Given this list of marker genes IKBKE, RNF185, YTHDF2, MUL1, NLRC5, TREX1, LSM14A, RBM47, USP27X, GIGYF2, IRF7, CNOT7, SAMHD1, MMP12, STING1, TBK1, CACTIN, SMIM30, METTL3, PTPN6, TTLL12, FADD, OAS3, STAT2, PTPN11, PTPN2, WNT5A, YTHDF3, OAS1, TRIM56, IRF3, MAVS, ISG15, USP29, TRIM41, UBE2K, DCST1, MIR21 (NCBI Gene Id 406991), PTPN1, USP18, ADAR, CDC37, TRIM6, ZBP1, EIF4E2, here is a description of the gene set: studied in species Homo sapiens Human Gene Set: GOBP_REGULATION_OF_TYPE_I_INTERFERON_MEDIATED_SIGNALING_PATHWAY Any process that modulates the rate, frequency or extent of a type I interferon-mediated signaling pathway.